The following is a description of a gene set: studied in species Homo sapiens Any process that stops, prevents or reduces the rate of translation initiation as a result of a stimulus indicating the organism is under stress. Human Gene Set: GOBP_NEGATIVE_REGULATION_OF_TRANSLATIONAL_INITIATION_IN_RESPONSE_TO_STRESS, and this is the list of marker genes: EIF2S1, EIF2AK3, EIF2AK4, PML, ATF4